Given this list of marker genes CLK1, FCHSD2, HLA-DRA, HENMT1, TACSTD2, PLS1, LTBP2, MC5R, LGALS3, ID3, EFNB1, CYP4B1, NRP2, NRP1, PER3, IL36B, ARHGDIB, WDR45, GPR183, CD74, HEXB, SPRY2, MC4R, CCR1, HPGD, SELENOP, TREM2 (triggering receptor expressed on myeloid cells 2), YY1, SLF1, GPR6, HCST, LUM (lumican), HLA-DRB3, SFTPB (NCBI Gene Id 6439), CCR6, NPFFR2, AGR2, MAPK1, A2M, USP24, CXCR6, ASNS, MYC, PTP4A1, KCNJ2, PTP4A2, MC3R, PLEKHG2, IGHG1, here is a description of the gene set: Human Gene Set: HENDRICKS_SMARCA4_TARGETS_DN studied in species Homo sapiens from publication Hendricks KB, Shanahan F, Lees E (PMID 14673169) Human BRG1, a subunit of the Swi/Snf chromatin remodeling apparatus, has been implicated in regulation of cellular proliferation and is a candidate tumor suppressor. Reintroduction of BRG1 into a breast tumor cell line, ALAB, carrying a defined mutation in the BRG1 gene, induced growth arrest. Gene expression data revealed that the arrest may in part be accounted for by down-regulation of select E2F target genes such as cyclin E, but more dramatically, by up-regulation of mRNAs for the cyclin-dependent kinase inhibitors p21 and p15. Protein levels of both p15 and p21 were induced, and p21 protein was recruited to a complex with cyclin-dependent kinase, CDK2, to inhibit its activity. BRG1 can associate with the p21 promoter in a p53-independent manner, suggesting that the induction of p21 by BRG1 may be direct. Further, using microarray and real-time PCR analysis we identified several novel BRG1-regulated genes. Our work provides further evidence for a role for BRG1 in the regulation of several genes involved in key steps in tumorigenesis and has revealed a potential mechanism for BRG1-induced growth arrest. Genes down-regulated in ALAB cells (breast cancer) upon reintroduction of SMARCA4 expressed off adenoviral vector.